Given this list of marker genes VEGFC, KDR, FLT1, PGF, VEGFD, FLT4, VEGFA, VEGFB, here is a description of the gene set: part of: Signaling by VEGF The VEGF family is encoded by seven genes (VEGF-A, B, C, D, E: PLGF (Placenta Growth Factor)-1, 2). Six isoforms of VEGF-A protein, containing 121, 145, 165, 183, 189, and 206 amino acid residues, and two isoforms of VEGF-B (167 and 186 residues) are specified by alternatively spliced mRNAs. The active form of each of these proteins is a homodimer.<br>The specificities of the three VEGF tyrosine kinase receptors, VEGFR-1, VEGFR-2 and VEGFR-3, for these ligands are shown in the figure. All VEGF-A isoforms bind both VEGFR-1 and VEGFR-2; PLGF-1 and -2, and VEGF-B isoforms bind only VEGFR-1; VEGF-E binds VEGFR-2; and VEGF-C and -D bind both VEGFR-2 and -3. VEGF-D undergoes a complex series of post-translational modifications that results in secreted forms with increased activity toward VEGFR-3 and VEGFR-2. <br>Two co-receptor proteins in the cell membrane, neuropilin (NRP)-1 and NRP-2, interact with VEGFR proteins to increase the affinity of the latter for their ligands (Neufeld et al.,2002). They differ from VEGFR proteins in not having intracellular signaling domains. studied in species Homo sapiens Reactome Pathway: VEGF ligand-receptor interactions